Given this list of marker genes Cd9, Izumo3, Izumo1, Acr, Izumo4, Izumo2, here is a description of the gene set: part of: Fertilization Reactome Pathway: Acrosome Reaction and Sperm:Oocyte Membrane Binding electronically inferred by orthology from the curated human pathway This event has been computationally inferred from an event that has been demonstrated in another species.<p>The inference is based on the homology mapping from PANTHER. Briefly, reactions for which all involved PhysicalEntities (in input, output and catalyst) have a mapped orthologue/paralogue (for complexes at least 75% of components must have a mapping) are inferred to the other species. studied in species Mus musculus